The following is a description of a gene set: Genes having at least one occurrence of the motif SAAAAGYGAAACC in the regions spanning 4 kb centered on their transcription starting sites. This matches the IRF1 transcription factor binding site V$IRF1_01 (v7.4 TRANSFAC). Human Gene Set: IRF1_01 species: Homo sapiens, and this is the list of marker genes: TAP1, PGM5, CLCA3P, TAPBP, CNTF, MGAT2, PITX1, FAM13C, RIGI, NCOA1, NETO1, PRDX5, HDAC4, PAX2, LTBP2, UBD, CGA, LRP5, LCOR, KARS1, SMIM14, NRAS, RIT1, NOG (NCBI Gene Id 9241), RAPGEF6, IL17RC, PTPRR, ZBED5 (zinc finger BED-type containing 5), SEMA7A, GANAB, MAP3K11, NFIX, PSMA3, COL4A1, KLHDC7A, EHD1, NR3C2, DGKB, IFNB1, CASZ1, BLK, KPNA3, RTL9, AGBL2, TRIM8, DTX3L (deltex E3 ubiquitin ligase 3L), ATP13A1, SAT1, HLX, PIGV, PDGFC, TWIST1, DYNLT1, E2F3, ISG15, TGFB3, KDM3A, SALL2, DUSP10 (NCBI Gene Id 11221), EPAS1, MBD6, NABP2, ASPA, XAF1, F3, EGR2, CXCL11, SLC22A25, DLG1, PSMB10, EPYC, VAMP3, HOXA6, HOXB6, NPR3, PBDC1, H4C7, BCOR, PHF21A, PIGR, IRAG2, BST2, IL27, KANK4, AAK1, PRDM10, SPMIP5, RUNX1T1, IL9, TRPM3, RORB, HOXB7, LOX, DLX1, RELCH, PPARGC1A, EGFL6, PEX12, LDB2, STX17, ARHGAP5, CCDC68, BCL11A (BCL11 transcription factor A), USP18, BBX, CACNB2, GNAO1, IRF9, TNFSF13B, HPCAL1, XRN1, ELK4, ESR1, EDA, BEX3, PLXNC1, TMPRSS5, VGLL4, TFEC, PRKD3, CDK6, CD40LG, SLAMF8, B2M, MXI1, ASIC2, PSMB9, COL4A2, LGI1, TMEM108, LMO3, PRKCB, ELAVL4, TMEM229B, SMAD6, ZNF366 (zinc finger protein 366), PTGR3, ZPBP2, PRDM16, LSM6, VGLL3, LMO4, CDKN2A, DMD, ITGBL1, ACIN1, SYNE2, IFNL2, EN1, CA10, TRIM21, ROCK1, FLT3LG, TASL, CSAD, TLCD5, SLC25A14, BMP4, USP5, RUSC1-AS1 (RUSC1 antisense RNA 1), CCL5, MXD3, USP37, SREK1, BLNK, IKZF2, FBXO8, TMBIM4, HOXD9, GLRA1, BNC2, LIF, ATF3, ZSCAN2, HOXA13, ITPKB, ZNF362, DIO2, JKAMP (JNK1/MAPK8 associated membrane protein), IL15RA, CSTF3, RNF220, PARP9, CREB1, RMDN3, CHST11, PUM3, KYNU, CCDC140, MED13, FXYD5, IL11, ELOA2, CXCL10, DDIT3, IFNL3, USF1, NT5C3A, HOXA10, PLEKHB1, TBX1 (NCBI Gene Id 7413), FOXA1, KCNE4, BIRC8, SKAP1, PPP4R3B, LDB1, MITF, PROX1, DLX4, L3HYPDH, LEMD1, GATA6, ATP1B4, CEP44, DNASE1L3, SH3BGRL, GSDMD, DEPDC7, AKIRIN1, PSMB8, XPO4, ARHGEF6, CUL2, EIF4A2, STX11, DOCK9, NEPRO, SHANK2, GATA3, WNT8B, TLK2, AMER1, MARCHF1, PAX3, IL6, PITX2, TRMT112, OR3A2, NDN, EMX2, CD200R1, PCGF5, SCOC, RIMS2, AXIN1, HLA-C, VAX1, SZRD1, SORBS1, TERF2IP (TERF2 interacting protein), YWHAG, SLC22A17 (solute carrier family 22 member 17), FEZF2 (NCBI Gene Id 94016), ABHD16A